Given this list of marker genes TENT5C, SAMTOR, RSRP1 (arginine and serine rich protein 1), IFNGR1, CTDSP2, ADORA2A, OSER1, GLCCI1, PTTG1IP, NFATC3, CD5, ENTREP3, SLC43A2, TESK2, C16orf54, LDLRAP1, AP5S1, N4BP2L1, MTURN, DNAJB4, NARF (NCBI Gene Id 26502), AURKB, NEK1, ST8SIA1 (ST8 alpha-N-acetyl-neuraminide alpha-2,8-sialyltransferase 1), BCL6, CCNF, ALDH6A1, PIK3IP1, KIF21B, ZNF467, DHX40, BCL2L11, HOXD3, RPRD2, ATG12, MAP3K3, ARHGAP12, ZNF436, KDM4B, TOB1, UBE2T, RNF181 (NCBI Gene Id 51255), MSL3, RIPOR2, CDKN2AIP, CHST12, SESN1 (NCBI Gene Id 27244), DUSP10, IP6K1, GRAP, CCDC28A, ZBTB44, SASH3, DZIP1, BCL9, ASB3, RGS16 (regulator of G protein signaling 16), CCDC28B, OAZ2, CDIN1, ZNF274, ZFAND3, DUBR, KIF2C, SLA, TMUB2 (NCBI Gene Id 79089), ZNF667, CEP120, TNIP1, KLHL24, HROB, CCNG2, IL16, PGM2L1, ZPBP2 (zona pellucida binding protein 2), KIF20A, SLC38A7, SH3YL1, PPP2R5D, FAM117B, NBR1, USP28, GDPD3 (NCBI Gene Id 79153), PAIP2, TCF7, PECAM1, ACBD5, USP53, FRMD8, SENP7, SFR1, ING4, RPS6KA5, ATOSA, TTC9C, KCNN4 (NCBI Gene Id 3783), CTNS, FBXO32, INSR, GPATCH8, IKBKE, IRF9, IL7R, FBXL20, STX5, MTMR14, ANKRD46, MAT2B, IPCEF1 (interaction protein for cytohesin exchange factors 1), VIPAS39, RNF13, FAS, NGLY1, PNPLA8, SLC37A4, P4HA2, FAM221A, TNFAIP8L1, PXYLP1, ZYG11B, JDP2, TMIE, LRRC28, CREBRF, NRIP1, KIF18B, LZTFL1, TSC22D3, CDCA3, NEU3, ARHGAP45, ABHD4, UBE2H, L3MBTL3, MBNL2, SPATA13, FBXO25, ARMCX2, PIMREG, RBM4B, DIPK1A, ZNF395, EVL (NCBI Gene Id 51466), TSPAN32, CBLB, TRAF3IP3, TDRP, TMEM106B, S1PR4 (NCBI Gene Id 8698), YPEL2, SERTAD3, UEVLD, OXR1, ADD3, POT1, SSC4D, YPEL5, CYP2S1, MMP3, ARHGEF18, MAP2K6, ZNF512, CENPL, RDH12, ORC5, ZFAND4, KHNYN, SYNGR3, PIP4K2A, FOXO3, KIAA0040, RANBP10, PTGIR, HECA, CROT, GRAMD2B, ZC3H12D, LYPD6B, SH3RF1, DAPK2, OSBPL9, SPOP, OTUD1, CBX1, SGMS1, STK38, MDM1, CYTH3, HSDL1, SLAIN1, NATD1, GALNT9, ASAP1, MAF1, TMT1A, RETREG2, ARRDC3, MASTL, NDC80, TMEM71, here is a description of the gene set: We have previously shown that rheumatoid factors (RF) produced by Fas-deficient autoimmune-prone mice typically bind autologous IgG2a with remarkably low affinity. Nevertheless, B cells representative of this RF population proliferate vigorously in response IgG2a/chromatin immune complexes through a mechanism dependent on the sequential engagement of the BCR and Toll-like receptor 9 (TLR9). To more precisely address the role of both receptors in this response, we analyzed the signaling pathways activated in AM14 B cells stimulated with these complexes. We found that the BCR not only serves to direct the chromatin complex to an internal compartment where it can engage TLR9 but also transmits a suboptimal signal that in combination with the signals emanating from TLR9 leads to NF-kappa-B activation and proliferation. Importantly, engagement of both receptors leads to the upregulation of a group of gene products, not induced by the BCR or TLR9 alone, that include IL-2. These data indicate that autoreactive B cells, stimulated by a combination of BCR and TLR9 ligands, acquire functional properties that may contribute to the activation of additional cells involved in the autoimmune disease process. Genes up-regulated in B lymphocytes: anti IgM versus CpG oligodeoxynucleotide 1826. from publication Busconi L, Bauer JW, Tumang JR, Laws A, Perkins-Mesires K, Tabor AS, Lau C, Corley RB, Rothstein TL, Lund FE, Behrens TW, Marshak-Rothstein A (PMID 18025183) species: Homo sapiens Human Gene Set: GSE6674_ANTI_IGM_VS_CPG_STIM_BCELL_UP